The following is a description of a gene set: BCR-PLCG-ITPR signaling pathway. Pathway ID: N01463. Pathway type: Reference. Pathway class: nt06528 Calcium signaling. Pathway Definition from KEGG: IGH -> (LYN,SYK) -> (BTK,BLNK) -> PLCG2 -> IP3 -> ITPR -> Ca2+(cyto) Human Gene Set: KEGG_MEDICUS_REFERENCE_BCR_PLCG_ITPR_SIGNALING_PATHWAY species: Homo sapiens, and this is the list of marker genes: LYN, SYK, ITPR2, ENSG00000275063, ITPR3, PLCG2, BTK, ITPR1 (NCBI Gene Id 619543), BLNK